Given this list of marker genes FBL, RUVBL2, AHR, ERCC4, EDF1, NOP58 (NOP58 ribonucleoprotein), TP53, ERCC1, RUVBL1, ZNHIT6, here is a description of the gene set: Human Gene Set: GOMF_TFIID_CLASS_TRANSCRIPTION_FACTOR_COMPLEX_BINDING studied in species Homo sapiens Binding to a general RNA polymerase II transcription factor belonging to the TFIID complex, one of the factors involved in formation of the preinitiation complex (PIC) by RNA polymerase II.